Given this list of marker genes NUP210, SRRM1, SRSF2 (NCBI Gene Id 6427), SLU7, SEC13, CHTOP, U2AF1L4, NUP42, TPR, CDC40, ZC3H11A, POLDIP3, SRSF3, NUP133 (NCBI Gene Id 55746), THOC2, NUP35, U2AF2, RANBP2, NXF1, NUP155, THOC3, CASC3, NUP205, MAGOH, SRSF9, DDX39A, DHX38, SRSF11, SRSF6, NCBP2 (nuclear cap binding protein subunit 2), NDC1, RBM8A, THOC1, MAGOHB (mago homolog B, exon junction complex subunit), SRSF1, FYTTD1, THOC5, NUP107, SRSF4, NUP58, SEH1L, SRSF7 (NCBI Gene Id 87459), NUP93, AAAS, NUP85, SARNP, NXF2, NUP88, NUP188, LUZP4, NUP54, DDX39B, THOC7, GLE1, EIF4A3, NUP37, NUP62, NUP43, NUP98, U2AF1, UPF3B, POM121C, RNPS1, NUP160, SRSF5, NXT1, NUP50, NUP153, NCBP1, POM121, THOC6, RAE1, ALYREF, NUP214, here is a description of the gene set: Reactome Pathway: Transport of Mature mRNA derived from an Intron-Containing Transcript studied in species Homo sapiens Transport of mRNA from the nucleus to the cytoplasm, where it is translated into protein, is highly selective and closely coupled to correct RNA processing. This coupling is achieved by the nuclear pore complex, which recognizes and transports only completed mRNAs. part of: Transport of Mature Transcript to Cytoplasm